Given this list of marker genes WRAP53, TERT, SPDYA, USP7, BRCA2, POT1, ZNF827, NABP2 (nucleic acid binding protein 2), ACD, TERF1, TCP1, CCT6A, here is a description of the gene set: The directed movement of a protein to a specific location in the telomeric region of a chromosome. Human Gene Set: GOBP_ESTABLISHMENT_OF_PROTEIN_LOCALIZATION_TO_TELOMERE species: Homo sapiens